The following is a description of a gene set: Human Gene Set: MIR601 Genes predicted to be targets of miRBase v22 microRNA hsa-miR-601 in miRDB v6.0 with MirTarget v4 prediction scores > 80 (high confidence targets). from publication Chen Y, Wang X (PMID 31504780) species: Homo sapiens, and this is the list of marker genes: RO60, AHCTF1, TAF11, RTBDN, USP29, LURAP1L, SLC38A9, MBNL1, GOLGA8A, NLGN1, CASP3, PPP2R2D, SEC16B, EIF4EBP3, ANKRD31, ANKIB1, PCSK9, DDHD2, ALDH3A1, CNKSR2, SNRK, RSKR, LHFPL2 (NCBI Gene Id 285713), CUL3, SIRT1, HSPH1, SLC6A6, CSNK2A2, DTX4, KHDC4, NRG3, ZNF416, FBLN7, BCL2L2, GOLGA8B, B3GNT9, ZBTB38, EFNA4, RASGRP3